The following is a description of a gene set: The movement of a phospholipid molecule from one leaflet of a membrane bilayer to the opposite leaflet. Human Gene Set: GOBP_PHOSPHOLIPID_TRANSLOCATION studied in species Homo sapiens, and this is the list of marker genes: VMP1, XRCC4, ANO9, ABCA4, TRPC5, ATP8A1, PLSCR1, SERINC5, TMEM30A, ABCC1, ATP10A, P2RX7, SERINC2, XKR7, ATP8B4, ANO6, ATP8B2, PLSCR3, ATP9B, ATP11C, ATP10B, ATP8B3, CLPTM1L, VDAC2, TMEM41B, XKR8, ATP11B, ANO4, ABCA1, TMEM63B, ANO7, MFSD2A, ATP8A2, ANO3, ATG9A, ATG9B, PLSCR4, XKR4, PLSCR2, ABCA7, SLC4A1, XKR6, ATP9A, TMEM30B, ATP11A, ABCB4, SLC66A2, ATP8B1, KCNN4, ATP10D, TRIAP1, ABCB1, PLSCR5, XKR9, SERINC3, FASLG